Given this list of marker genes GLDC, AMT, GCSH, OGDH, DLST, DLD (dihydrolipoamide dehydrogenase), KGD4, here is a description of the gene set: part of: Glyoxylate metabolism and glycine degradation studied in species Homo sapiens Reactome Pathway: Glycine degradation The simplest amino acid, glycine, is catabolised by several different pathways. The major pathway is via the glycine cleavage system, comprising dimeric P protein (GLDC), T protein (AMT, GCST), dimeric L protein (DLD) and H protein (GCSH).